Given this list of marker genes SLC25A15, OTC, NAGS, SLC25A13, GLS2, ASL, ARG1, CPS1, ASS1, here is a description of the gene set: Human Gene Set: WP_UREA_CYCLE_AND_RELATED_DISEASES Urea cycle and related diseases studied in species Homo sapiens